The following is a description of a gene set: Mouse Gene Set: GOMF_2_OXOGLUTARATE_DEPENDENT_DIOXYGENASE_ACTIVITY Catalysis of the reaction: A + 2-oxoglutarate + O2 = B + succinate + CO2. This is an oxidation-reduction (redox) reaction in which hydrogen or electrons are transferred from 2-oxoglutarate and one other donor, and one atom of oxygen is incorporated into each donor. species: Mus musculus, and this is the list of marker genes: P4hb, Hif1an, Kdm1a, Kdm6b, Egln2 (NCBI Gene Id 97399), P3h2, Jmjd7, Tyw5, Alkbh1, Kdm4a, Kdm3b, Kdm6a, Plod2, Kdm2b, Asph, Alkbh8, Phyh, Phf2, P4ha2, Riox2, P3h3, Jmjd6, Alkbh2, Alkbh7 (NCBI Gene Id 70288), Alkbh6, Kdm5a, Kdm8, Tet2, Phf8, Hspbap1, P3h1, Tet1, P4ha3, Kdm5c, Kdm4c, Bbox1, Hr, Jmjd4, Alkbh4, Kdm3a, Alkbh5, Fto, Kdm4d, P4htm, Kdm5d, Rsbn1, Plod1, Alkbh3, Kdm4b, Egln1, Riox1, Plod3, Kdm2a, Phyhd1, P4ha1, Kdm5b, Uty, Ogfod1, Kdm7a, Egln3, Tet3, Kdm1b